The following is a description of a gene set: Any process that results in a change in state or activity of a cell or an organism (in terms of movement, secretion, enzyme production, gene expression, etc.) as a result of a stimulus reflecting an increase in the level of oxygen. studied in species Mus musculus Mouse Gene Set: GOBP_RESPONSE_TO_INCREASED_OXYGEN_LEVELS, and this is the list of marker genes: Mmp2, mt-Cytb, Foxo1, Col1a1, Kcna5, Slc4a1, Atp6v1g1, Ccr2, mt-Atp6, Cat, Epo, Tmem199, Polb, Cyp1a1, Nox1, Atg7, Atp6v1a, Cdkn1a, Fas, Slc7a5 (solute carrier family 7 (cationic amino acid transporter, y+ system), member 5), Atp6v0d1, Cav1, Bnip3, Ccdc115, Atp6ap1, Sod2, Atp6v0a2